The following is a description of a gene set: Human Gene Set: REACTOME_SARS_COV_2_ACTIVATES_MODULATES_INNATE_AND_ADAPTIVE_IMMUNE_RESPONSES species: Homo sapiens SARS-CoV-2 activates/modulates innate and adaptive immune responses, and this is the list of marker genes: NUP85, NUP37, IFNA5, IFNB1 (interferon beta 1), HSP90AA1, HLA-E, PIK3C3, HSP90AB1, TPR, PTPN6 (protein tyrosine phosphatase non-receptor type 6), RIPK2, NLRP3, PTPN11, CHUK, G3BP2, NOD2, TLR1, RPS27A, STAT1, IFNA4, UBA52, IFNA21, SEC23A, IFNA10, IKBKG, MAP3K7, G3BP1, CNBP, NUP93, NUP133, POM121C, TLR7, HLA-C, PIK3R4, IFNA2, HLA-B, IFNA13, ISG15, B2M, SAR1B, IL17F, SEC13, IFNA8, NUP153, MASP1, TRAF6, NUP188, POM121, NUP62 (nucleoporin 62), TRIM4, RAE1, UBB, IKBKE, IRAK1, IFIH1, TBK1, NUP58, NUP50, IRF3, RANBP2, NUP35, SEC24B, NUP210, IL17RA, TRAF3, IFNAR1, HLA-A, NUP88, SFTPD, TLR2, MAVS, CREBBP, HLA-G, IFNA16, TLR8 (NCBI Gene Id 92553), SEC24A, IL17RC, IFNA6, SIKE1, TYK2, IKBKB, NOD1, MASP2, TAB1, IFNA14, NUP54, RIGI, UBE2N, JAK1, NUP43, STAT2, NUP107, NUP98, IFNA17, NDC1, LARP1, KPNA2, BECN1, IFNA1, TRIM25, TAB2, RNF135, NUP205, ATG14, HLA-F, UBC, TOMM70 (translocase of outer mitochondrial membrane 70), IRAK2, IFNA7, UBE2V1, SEH1L, MBL2, NLRP12, NUP42, TKFC, TAB3, NUP214 (nucleoporin 214), IL17A, SEC24C, AAAS, NUP155, IRF7, SEC24D, NUP160, IFNAR2, STING1 (stimulator of interferon response cGAMP interactor 1)